Given this list of marker genes DST, MYBPC2, MYOM3, SMTNL1, MYL7, PPP1R12A, ANK2, PPP2R5A, KLHL40, ANK1, MYOM2, LRRC39, KCTD6, LMOD2, PPP1R12B, ENO1, MYL2, MYBPC3, MYL4, TTN, KLHL41, OBSCN (obscurin, cytoskeletal calmodulin and titin-interacting RhoGEF), SMPX, S100A1, UNC45B, CRYAB, MYOM1, MYBPC1, MYH1, CMYA5, MYBPH, KAT2B, ALDOA, MYL3, SPTBN1, NBR1, OBSL1, SLMAP, LMOD3, TRIM63, ATP2A1, here is a description of the gene set: The dark-staining region of a sarcomere, in which myosin thick filaments are present; the center is traversed by the paler H zone, which in turn contains the M line. Human Gene Set: GOCC_A_BAND species: Homo sapiens